Given this list of marker genes RHOG, SNORD104 (NCBI Gene Id 692227), PDP2, ZBTB32, STX11, TRMT44, IL19, ZC3H15, NUP88, MAGOH2P, RIF1, NUP188, TMEM138, TRA2B, PSMD12, NDEL1, RAB30-DT, MAPKAPK2, RAB8B, PPIF, KRR1, NUP54, POLR2D, NFATC1, CDKN3, PISD, RAB21, PGAM5, COPRS, ARL5B, DCAF13, TCP1, HNRNPAB, STAG3L4, RILPL2, RYBP, FOSL1, PPP2R2A, PITPNB, RRP9, NFYA, UTP14A, ETF1, RBM8A, USP12, CAMTA1, IRF4, FEM1A, PIGT, TTF2, UAP1, SEL1L, UMPS (uridine monophosphate synthetase), GPATCH4, MIR21, SLIRP, CEBPZ, HIF1A, STRIP2, NFIL3, SLC3A2, SPRING1, RGCC, FOS, BICDL1, EMC8, MRPS30, APOC2, KBTBD8, DHX30, NOC3L, RRP12, ICAM1, PKM, PIM2, TIMM44, WDR3, B3GALT6, GNPDA1, NAA20, MAIP1, DUSP12, CD83, UTP20, NUDCD1, RRN3, SLC19A2, SNORA21, PPP1R15B, ATG101, ZBTB39 (zinc finger and BTB domain containing 39), SNHG3, PITRM1-AS1, VDAC2, RIOK1, TXLNA, ZDHHC16, POLR2K, SLC7A5, ZC3H8, IARS1, RRS1, ZNF267, NIP7, SERPINB9, TAF9, BATF3, EBNA1BP2, SOCS4, TIMM8A, ABCF1, TRMT1, DDX31, BEND3, GFOD2, LTV1, NAB2, OTUD7B, MAFK, AMD1, IL23A, KSR1, MRPS35, BTG2, EVI5, DNLZ, TRAF1, RELB, CPD, PITRM1, EIF3B, CRIM1, ADPGK, SDCBP, CSF1, PABPC4, LRRC59, RBM4, DDX10, KPNA1, IL12A, QSOX2, ZNF614, MIR17HG, KPNA4, SRR, GEMIN5, PLEKHA3, SLC30A3, THUMPD2, PPTC7, TGS1, BUD23, SELENOI, NIPA1, MRPS7, TRMT10C, BRAF, MTERF3, TMEM33, LMNA, CLCF1, TIPIN, PHLPP2, ARIH2, TSFM, TET3, TMX2, BRIX1, SDF4, SPAG1, EMC6, IDI2, NIPA2, ITPRIPL2, ASPHD1, VMP1, ARHGEF2, GPN2, NXT1, ADSS2, MAP3K8, LRPPRC, BAZ1A, C1orf52, PLAGL2, NDUFAF4, TFRC, PDCD2L, CSNK2A1, URB2, IFT57, EIF6, NADK (NAD kinase), OTUD4 (NCBI Gene Id 95936), SMOX, KANSL2, here is a description of the gene set: from publication Gattinoni L, Lugli E, Ji Y, Pos Z, Paulos CM, Quigley MF, Almeida JR, Gostick E, Yu Z, Carpenito C, Wang E, Douek DC, Price DA, June CH, Marincola FM, Roederer M, Restifo NP (PMID 21926977) Human Gene Set: GSE23321_EFFECTOR_MEMORY_VS_NAIVE_CD8_TCELL_DN studied in species Homo sapiens Genes down-regulated in CD8 T cells: effector memory versus naïve. An early-differentiated CD8+ memory T cell subset with stem cell-like properties (TSCM) can be identified within the naïve-like T cell population by the expression of CD95/Fas. Based on experiments including exon- and gene-level expression analysis, we provide evidence that this subset of antigen-specific cells represents an early precursor of conventional central (TCM) and effector (TEM) memory CD8+ T cells with enhanced self-renewal capacity and proliferative potential. We identified genes differentially expressed between major T cell subsets defined along with memory T cell commitment. Based on the analysis of these genes, CD95+ naïve T cells (TSCM) cluster closer to the CD8+ T memory compartment than to classical (CD95-) naïve T (TN) cells, and display an intermittent phenotype between classical TN and TCM cells in terms of all major T cell differentiation markers analyzed.